The following is a description of a gene set: species: Mus musculus Any process that results in a change in state or activity of a cell or an organism (in terms of movement, secretion, enzyme production, gene expression, etc.) as a result of an interleukin-13 stimulus. Mouse Gene Set: GOBP_RESPONSE_TO_INTERLEUKIN_13, and this is the list of marker genes: Il13ra2 (NCBI Gene Id 16165), Shpk, Alox15, Cd300lf, Fosl2, Ccl11, Il13